Given this list of marker genes TNFRSF10B, TNFRSF10D, CASP10, FADD, CASP8, CFLAR, TNFSF10, TNFRSF10A, here is a description of the gene set: Reactome Pathway: TRAIL  signaling species: Homo sapiens Tumor necrosis factor-related apoptosis-inducing ligand or Apo 2 ligand (TRAIL/Apo2L) is a member of the tumor necrosis factor (TNF) family. This group of apoptosis induction pathways all work through protein interactions mediated by the intracellular death domain (DD), encoded within the cytoplasmic domain of the receptor. TRAIL selectively induces apoptosis through its interaction with the Fas-associated death domain protein (FADD) and caspase-8/10 (Wang S & el-Deiry WS 2003; Sprick MR et al. 2002). TRAIL and its receptors, TRAIL-R1 and TRAIL-R2, were shown to be rapidly endocytosed via clathrin-dependent and -independent manner in human Burkitt's lymphoma B cells (BJAB) (Kohlhaas SL et al. 2007). However, FADD and caspase-8 were able to bind TRAIL-R1/R2 in TRAIL-stimulated BJAB cells at 4<sup>o</sup>C (at which membrane trafficking is inhibited), suggesting that the endocytosis was not required for an assembly of the functional TRAIL DISC complex. Moreover, blocking of clathrin-dependent endocytosis did not interfere with the capacity of TRAIL to promote apoptosis (Kohlhaas SL et al. 2007).<br> part of: Death Receptor Signaling